The following is a description of a gene set: studied in species Homo sapiens Any process that decreases the rate, frequency or extent of release of cytochrome c from mitochondria, the process in which cytochrome c is enabled to move from the mitochondrial intermembrane space into the cytosol, which is an early step in apoptosis and leads to caspase activation. Human Gene Set: GOBP_NEGATIVE_REGULATION_OF_RELEASE_OF_CYTOCHROME_C_FROM_MITOCHONDRIA, and this is the list of marker genes: GHITM, FXN, HIGD1A, PSMD10, CLU, HGF, TRIAP1, AKT1, IGF1, IFI6, PRKN, PARL, NOL3, PPIF, BAK1, GPX1, PRELID1, OPA1, LMNA, BCL2L1